Given this list of marker genes NAMPT, SRSF10, TK1, ASF1B, COQ3, MARCHF5, SLC25A16, IDH3A, SLC9A6, HCCS, FASTKD3 (FAST kinase domains 3), SERP1, TMEM50B, NDRG1, BCAP31, OTUD6B, CKS2, DR1, RFC5, SET, MRPL39, FLCN, DHPS, KIF23, JAGN1, DEPDC1B, TM7SF3, SLC12A2, CAT, PLSCR1, TRA2B, SLC43A3, GRM4, TMED10, DIDO1, DLAT (NCBI Gene Id 1737), ACOT9, TUBB2A, SLBP, FBXO45, TNPO1, CDC7, MCM9, PLEKHH1, GMCL1 (NCBI Gene Id 64395), MTAP (NCBI Gene Id 8008), LMAN2L, FARP1, NHLRC3, PCSK9, CDCA4, ATG10, NPAT, BUB1B, OR51E1, REEP3, SELENOH, SOD2, SOCS4, BMP2K, RBM7, GINS3, SPDL1, CNOT7, SRRM1, ANLN, IDE, CBX3, WNK4, EMC2, TULP4, CENPA, TMEM59, RAB21, SEC23IP, SGO2, SGCB, FIRRM, VASH1, LAMTOR3, KIF22, SLC25A4, DPY19L1, MRPL15, TIAM1, ZC3H14, PSPC1, CHMP4B, CENPF, ZNF264, CDC25C, FDFT1, TRIM27, ZDHHC21, MAP2K4, E2F2, VMA21, AURKB, SMARCC1, MBTPS2, ANXA2, TMEM97, COG7, PTPN12, RAPGEF2, MYCBP, ATF2, NIN, LPIN2, NUDT4, CHORDC1, EAF1, RTN3, SLAIN2, RAD21, GTF2B (NCBI Gene Id 2959), RAB14, ZC2HC1C, SYCE2, METTL9, PDS5B, CUL4B, GSR, DNAJC6, MYO5A, ARFIP1, FRMD4B, GAPVD1, CYP20A1, RAD51C, PTGR2, SNIP1, FIRRE, ERO1B, BACH1, LIN9, POGZ, RBM14, GOLPH3, PARG, MAP3K7, FAM91A1, MTHFD1L, C2orf69, ACTR3, KCMF1, CSTF2, MIS18A, DCTPP1, TRAK2, YTHDF1, ACO1 (NCBI Gene Id 48), ZBTB2, NIPA2, ASXL1, NARS1, CMSS1, DNPH1 (2'-deoxynucleoside 5'-phosphate N-hydrolase 1), SNX18, ACTL6A, EPS15L1, ZNF507, YWHAZ, MCM2, PRC1, UBA3, B9D1, GRSF1, CENPI, BTBD10, RNASEH2B, CPNE1, SKAP2, EPS15, EMC6, SNX10, THOC7, CHCHD4, IBTK, PON2, MIER3, KIFC1, TMEM183A, TNFRSF9, AP1G1, AGPAT4, VKORC1L1, GPSM2, PPP2R5E, SNX16, ITPR1, FBXO9, LDLRAD4, MCM4, NCAPH, ALDH9A1, CDC20, LRR1, AP3S1, CCDC34, here is a description of the gene set: from publication Sarkar S, Kalia V, Haining WN, Konieczny BT, Subramaniam S, Ahmed R (PMID 18316415) Human Gene Set: GSE10239_MEMORY_VS_KLRG1HIGH_EFF_CD8_TCELL_DN Genes down-regulated in comparison of memory CD8 T cells versus effector CD8 T cells KLRG1 high. studied in species Homo sapiens Using killer cell lectin-like receptor G1 as a marker to distinguish terminal effector cells from memory precursors, we found that despite their diverse cell fates both subsets possessed remarkably similar gene expression profiles and functioned as equally potent killer cells. However, only the memory precursors were capable of making IL-2 thus defining a novel effector cell that was cytotoxic, expressed granzyme B, and produced inflammatory cytokines in addition to IL-2. This effector population then differentiated into long-lived protective memory T cells capable of self-renewal and rapid re-call responses. Mechanistic studies showed that cells that continued to receive antigenic stimulation during the later stages of infection were more likely to become terminal effectors. Importantly, curtailing antigenic stimulation towards the tail-end of the acute infection enhanced the generation of memory cells. These studies support the decreasing potential model of memory differentiation and show that the duration of antigenic stimulation is a critical regulator of memory formation